The following is a description of a gene set: studied in species Homo sapiens Human Gene Set: GOBP_POSITIVE_REGULATION_OF_BINDING Any process that activates or increases the rate or extent of binding, the selective interaction of a molecule with one or more specific sites on another molecule., and this is the list of marker genes: POU4F1, BDNF, RPL11, PARP9, CDT1, USP33, MED25, RB1, IDE, ADD2, DTX3L, DAZAP2, RAPGEF2, NVL, NMD3, TXN, STMN1, EIF3C, TIAM1, NCBP1, BMP4, GMNN, TRIM6, ABL1, EIF4G1, TWIST1, GTF2B, TERT, NIBAN2, DPH3, POU4F2, CLN5, IGF1, TRIM21, IFNG (NCBI Gene Id 3458), USP9X, DDX11, SKI, MET, AKTIP, GPSM1, EGF, RIPOR1, RARA, NEUROD1, HAND2, PYHIN1, FLOT1, RALB, EPHA4, MMP9, GSK3B (NCBI Gene Id 2932), EIF3E, SUMO4, RAN, EDF1, SIRT2, ADD1, DACT1, H1-0, HMGB1 (high mobility group box 1), EPB41, PLAUR (plasminogen activator, urokinase receptor), HES1, NME1, FOXC1, KDM4D, CEBPG, BAMBI, PINX1, GATA3, RIPOR2